The following is a description of a gene set: Premature closure of the coronal suture of skull. Human Gene Set: HP_CORONAL_CRANIOSYNOSTOSIS Coronal craniosynostosis species: Homo sapiens, and this is the list of marker genes: RNU12, CTSK, RECQL4, SEC24D (SEC24 homolog D, COPII coat complex component), ZEB2, MSX2, CCBE1, SLC25A24 (NCBI Gene Id 92093), TCOF1, H4C9, PIGO, P4HB, TCF12, EFNB1, ERF, SCUBE3, AHDC1, RAB23, BPNT2, SPECC1L, FGFR3, POLA1, FGFR2, FGFR1, POR, TWIST1, GTF2E2, IL11RA, ALX4, ZIC1, SMO, MASP1, CEP120